Given this list of marker genes BIRC5, UBE2C, HAUS1 (HAUS augmin like complex subunit 1), ZMYM2, CENPU, H4C3, CCDC34, ILF3, MYBL2, CDK6, ADCY3, EIF4EBP1 (NCBI Gene Id 1978), RRM2, TMEFF1, CCNA2, HMGB3, CDC25A, ATAD2, KIF14, DTYMK (NCBI Gene Id 9102), PAFAH1B3, NASP, CKS1B, CENPA, MKI67, POLE2 (DNA polymerase epsilon 2, accessory subunit), RNASEH2A, MCM7, TPX2 (TPX2 microtubule nucleation factor), CDK4, UHRF1, POLQ, MLLT11, RECQL4 (RecQ like helicase 4), ZNF367, H2AX, MFN2, CKAP2, NEK2, KLKB1, UBE2T (ubiquitin conjugating enzyme E2 T), ODC1, BCAT1, NUDT1, MEX3B, ADGRL3, PTTG1, JPT1, DLGAP5, ZWINT, MAD2L1 (mitotic arrest deficient 2 like 1), CCNB2, NME1, ENO1, MELK, GPX7, GGH, RFC4, CDCA7, SLC25A40, PLK4, CENPN, PSAT1, GAPDH, CDCA2, PBK, DNMT1, SNRNP200, ILF2, NSD2, GINS2, TK1, CKS2, NUF2, RFC3, KIF11, NCAPH, TTK, ASF1B, SNORD22, CDCA8, SOX4, DBF4, TWIST1, EIF4A1, ESPL1, KPNA2, E2F1, RCC2, CENPF, ZNF300, NUSAP1, AURKA, PRC1 (NCBI Gene Id 9055), PCNA, MCM4, MND1, MYCN, DHFR, CDC45, LMNB2, TMPO, TUBA1A, PON3 (NCBI Gene Id 94886), MCM5, CDK1, CCNT1, CENPE, TYMS, RRP1 (ribosomal RNA processing 1), SMC4, STMN1, BUB1, GABRB2, CCNB1 (cyclin B1), TOP2A, CDCA5, here is a description of the gene set: studied in species Homo sapiens Human Gene Set: WHITEFORD_PEDIATRIC_CANCER_MARKERS Human tumor xenografts have been used extensively for rapid screening of the efficacy of anticancer drugs for the past 35 years. The selection of appropriate xenograft models for drug testing has been largely empirical and has not incorporated a similarity to the tumor type of origin at the molecular level. This study is the first comprehensive analysis of the transcriptome of a large set of pediatric xenografts, which are currently used for preclinical drug testing. Suitable models representing the tumor type of origin were identified. It was found that the characteristic expression patterns of the primary tumors were maintained in the corresponding xenografts for the majority of samples. Because a prerequisite for developing rationally designed drugs is that the target is expressed at the protein level, we developed tissue arrays from these xenografts and corroborated that high mRNA levels yielded high protein levels for two tested genes. The web database and availability of tissue arrays will allow for the rapid confirmation of the expression of potential targets at both the mRNA and the protein level for molecularly targeted agents. The database will facilitate the identification of tumor markers predictive of response to tested agents as well as the discovery of new molecular targets. from publication Whiteford CC, Bilke S, Greer BT, Chen Q, Braunschweig TA, Cenacchi N, Wei JS, Smith MA, Houghton P, Morton C, Reynolds CP, Lock R, Gorlick R, Khanna C, Thiele CJ, Takikita M, Catchpoole D, Hewitt SM, Khan J (PMID 17210681) Differentially expressed genes in a panel of xenografts representing 8 common pediatric tumors compared to the normal tissues.